The following is a description of a gene set: Abstract of publicaton: CD4/CD8 double-positive (DP) thymocytes express the transcriptional repressor Histone Deacetylase 7 (HDAC7), a class IIa HDAC that is exported from the cell nucleus after T cell receptor (TCR) engagement. Through signal-dependent nuclear export, class IIa HDACs such as HDAC7 mediate signal-dependent changes in gene expression that are important to developmental fate decisions in multiple tissues. We report that HDAC7 is exported from the cell nucleus during positive selection in thymocytes, and regulates genes mediating the coupling between TCR engagement and downstream events that determine cell survival. Thymocytes lacking HDAC7 are inefficiently positively selected due to a severely shortened lifespan and exhibit a truncated repertoire of TCR Jalpha segments. The expression of multiple important mediators and modulators of the response to TCR engagement is altered in HDAC7-deficient thymocytes, resulting in increased tonic MAP kinase activity that contributes to the observed loss of viability. Remarkably, the activity of Protein Kinase D, the kinase that mediates nuclear export of HDAC7 in response to TCR signaling, is also increased in HDAC7-deficient thymocytes, suggesting that HDAC7 nuclear export governs a self-sustaining auto-excitatory loop. These experiments add to the understanding of the life/death decision in thymic T cell development, define a novel function for class IIa HDACs, and point to a novel feed-forward mechanism whereby these molecules regulate their own state and mediate stable developmental transitions. Title of manuscript: Nuclear Export of Histone Deacetylase 7 During Thymic Selection Mediates Immune Self-tolerance. abstract of manuscript: Histone Deacetylase 7 (HDAC7) is a TCR signal-dependent regulator of differentiation that is highly expressed in CD4/CD8 double-positive (DP) thymocytes. Here we examine the effect of blocking TCR-dependent nuclear export of HDAC7 during thymic selection, through expression of a signal-resistant mutant of HDAC7 (HDAC7-delta-P) in thymocytes. We find that HDAC7-delta-P Transgenic thymocytes exhibit a profound block in negative thymic selection, but can still undergo positive selection, resulting in the escape of autoreactive T cells into the periphery. Gene expression profiling reveals a comprehensive suppression of the negative selection-associated gene expression program in DP thymocytes, associated with a defect in the activation of MAP kinase pathways by TCR signals. The consequence of this block in vivo is a lethal autoimmune syndrome involving the exocrine pancreas and other abdominal organs. These experiments establish a novel molecular model of autoimmunity and cast new light on the relationship between thymic selection and immune self-tolerance. Goal of Microarray experiment: We did these experiments to determine how alteration of the function of HDAC7, a site-specific and signal-dependent repressor of transcription, changes gene expression in CD4/CD8 DP thymocytes. Human Gene Set: GSE26488_HDAC7_KO_VS_VP16_TRANSGENIC_HDAC7_KO_DOUBLE_POSITIVE_THYMOCYTE_DN from publication Kasler HG, Young BD, Mottet D, Lim HW, Collins AM, Olson EN, Verdin E (PMID 21398603) species: Homo sapiens Genes down-regulated in double positive thymocytes: HDAC7 knockout versus over-expressing HDAC7 fused with VP16., and this is the list of marker genes: TSNAX, SRXN1, NCOA2, USP15, PCP4, S100G, LHX1 (LIM homeobox 1), RTN1, GTF2A1, PDYN (NCBI Gene Id 5173), RAD17, ZNF362, CYBA, PLA2G10, CALCB, ZP2, CIAO2A, ALAS1, EGFL8, VPS26A (VPS26 retromer complex component A), KCTD9, UBL3, CCL22, SEPSECS, NAT2, TNFSF9, SPAST, IL1R2, CAB39L, PRKD1, HLA-G, TM7SF3, CDC42SE2, TPH1, CYP3A43, TTK, FBXL12, IL7R, ARL6IP1, ENTPD4, AANAT, SDHAF1, ZDHHC14, GUCY2C, KRT77, TFAP2C, NDRG4 (NDRG family member 4), CXCL13, JAGN1, GSS, GDAP2, UBXN1, ADIPOR2 (adiponectin receptor 2), SLC34A1, NAT1, TNFRSF11B, PPARG, DDX19A, SGPL1, NXPH2, RASD1, RAD50, NAA38, AK2, PNKD, CRP, SLC5A1, FCRLA, VDR, SLC25A11, RNASEH2B, MIA, CD80, IGDCC3, S100A3, PKIA (NCBI Gene Id 5569), SNCG, CYP26A1, FABP5, BCHE, IL12A, PGAP4, CALML5, GAD1, PLK4, MYB, ATOH7, RAB8A, ERO1A, GLA, CSF2RB, ATP6V1B2, ARHGEF3 (Rho guanine nucleotide exchange factor 3), RRM2B, CWC15, TMED1, SUMO3, BMP2K, PTGER3, CCR6, MRPL13, PLEKHB2, TBCEL, TFAP2B, HSPA14, BDKRB1, PSME2, APOM, TTC1, EOMES, APOC2, RAB17, PLD1, TEF, PRPF6, PRKCA, GALNT11, SCIN, P2RX4, SYT17, LAMP1 (lysosomal associated membrane protein 1), SULT1B1, CD200, MICOS10, ITIH1, DCTN3 (NCBI Gene Id 11258), SARAF, IFT25, EPHX2, DOCK5, TNFRSF9, FGF4, MAS1, SLC7A7, ACAD9, FNDC7, EBI3, SELENOK, ADH4, ABCB1, CDC7, HLA-DOA, HLA-DMB, SIRT1, RGS16, ADRB2, TMEM134, SPATA6, NEDD1, ETFBKMT, PKIG, MAP3K1, CYP27B1, EBF2, LXN, HPCA, CACNA1S, CYTIP, GDI1, PITPNC1, USP8 (NCBI Gene Id 9101), SPPL3, NCOA4, STAM2, NUCB1, ANTXR2, SDSL, THRSP, TM4SF5, CD70, ADIPOQ, RNF14, SP3, TFCP2L1, F11R, APBA2, PIK3C3, SEL1L, VAMP8, LACTB2, RASA3, F2, ADPRM, CTSS, DNM2, NDUFA1, KCNJ3, NSMCE3, ATP6V0E1, EIF4ENIF1, MFSD4A, KRT20, IL12B, GAS7, MST1, CADPS, ARF4, SLCO5A1, CDK14, HSPA4L